The following is a description of a gene set: Any process that results in a change in state or activity of a cell or an organism (in terms of movement, secretion, enzyme production, gene expression, etc.) as a result of an activity stimulus. species: Mus musculus Mouse Gene Set: GOBP_RESPONSE_TO_ACTIVITY, and this is the list of marker genes: Ntrk1, Metrnl, Fndc5, Mtfp1, Perm1, Kdm6b, Gclm, Fos, Fn1, Mir680-1, Mir705, Postn, Cdk1, Sco2 (NCBI Gene Id 100126824), Abcg5 (NCBI Gene Id 27409), Cat, Adipoq, Ppard, Lep, Tomm20, Slc38a2, Myh2, Cab39, Th, Ucp3, Hspa8, Il6, Slc25a25, Anxa2, Sod2, Atp5f1a, Abcc9, Cry1, Alad, Mir762, Agtr1a (angiotensin II receptor, type 1a), Adsl, Mir21a, Tnf, Mir680-2, Selenon, Oxt, Gclc, Ccl2, Capn3, Cbl, Cry2, Angpt2, Tns2, Myh4, Abcg8, Myhas, Dag1, Smtnl1, Il10, Pck1, Mmp2, Slc4a1, Prkag3, Mstn, Rnf170, Star, Prkdc, Ryr2, Kl, Fkrp, Col6a1 (NCBI Gene Id 12833), Col4a2, Prkaa1, Ppargc1a, Zeb1 (NCBI Gene Id 73165), Srl, Itgb3, Lncbate10, Atp1a3, Hadh (NCBI Gene Id 99932), Myog, Pik3ca, Stk11, Prkaa2, Agt, Edn1, Gpam, Mir709, Hif1a, Bmp6, Mir680-3, Slc7a5, Uqcrc1, Itga5, Itgb1, Phox2b, Itga2, Gcg, Mas1, Bloc1s6